The following is a description of a gene set: A protein complex that binds to, and promotes stabilization of, mRNA molecules containing the coding region instability determinant (CRD). In human, it may consist of IGF2BP1, HNRNPU, SYNCRIP/HNRNPQ, YBX1, and DHX9. Human Gene Set: GOCC_CRD_MEDIATED_MRNA_STABILITY_COMPLEX species: Homo sapiens, and this is the list of marker genes: CSDE1, SYNCRIP, HNRNPU, IGF2BP1, DHX9, YBX1